Given this list of marker genes KIT, LYN, STAT5A, RAC2 (NCBI Gene Id 5880), KITLG, here is a description of the gene set: studied in species Homo sapiens Any process that activates or increases the rate or extent of mast cell proliferation. Human Gene Set: GOBP_POSITIVE_REGULATION_OF_MAST_CELL_PROLIFERATION